Given this list of marker genes FBP1, IFI6, IGHE, BMAL1, C2CD2L, FUT9, HBEGF, PRB1, TRIM26, RARRES2, GNS, MSX1, MAPK8, PDYN, CNP, CPA3, MFAP4, CREM, OASL, HSD17B1P1, OMD, NF2, CH25H, HTR3A, SOX10, TNFSF9, SLC6A8, PTGDS, ASCL1, C4BPB, MNDA, CEACAM6, BTRC, C4BPA, PPP1R13B, AFF2, JMJD6, UNC93A, ISG15, MPL, RIPK1, MSLN, IFNB1, EIF2AK2, SLC6A6, COL2A1, VIL1, HLF, OAS1, MARK2, IFFO1, AMD1, FRMD4B, SFPQ, IRF7, ABCC5 (ATP binding cassette subfamily C member 5), PNP, CDR2L (NCBI Gene Id 30850), TNNT2, FOXJ1, MX1, OTUD3, EZH2, here is a description of the gene set: from publication Browne EP, Wing B, Coleman D, Shenk T (PMID 11711622) Human Gene Set: BROWNE_HCMV_INFECTION_6HR_UP The effect of human cytomegalovirus (HCMV) infection on cellular mRNA accumulation was analyzed by gene chip technology. During a 48-h time course after infection of human diploid fibroblasts, 1,425 cellular mRNAs were found to be up-regulated or down-regulated by threefold or greater in at least two consecutive time points. Several classes of genes were prominently affected, including interferon response genes, cell cycle regulators, apoptosis regulators, inflammatory pathway genes, and immune regulators. The number of mRNAs that were up-regulated or down-regulated were roughly equal over the complete time course. However, for the first 8 h after infection, the number of up-regulated mRNAs was significantly less than the number of down-regulated mRNAs. By analyzing the mRNA expression profile of cells infected in the presence of cycloheximide, it was found that a minimum of 25 mRNAs were modulated by HCMV in the absence of protein synthesis. These included mRNAs encoded by a small number of interferon-responsive genes, as well as beta interferon itself. Cellular mRNA levels in cytomegalovirus-infected cells were compared to the levels in cells infected with UV-inactivated virus. The inactivated virus caused the up-regulation of a much greater number of mRNAs, many of which encoded proteins with antiviral roles, such as interferon-responsive genes and proinflammatory cytokines. These data argue that one or more newly synthesized viral gene products block the induction of antiviral pathways that are triggered by HCMV binding and entry. Genes up-regulated in primary fibroblast cell culture point after infection with HCMV (AD169 strain) at 6 h time point that were not up-regulated at the previous time point, 4 h. species: Homo sapiens